The following is a description of a gene set: studied in species Homo sapiens from publication Hutcheson J, Scatizzi JC, Siddiqui AM, Haines GK 3rd, Wu T, Li QZ, Davis LS, Mohan C, Perlman H (PMID 18275831) Human Gene Set: GSE10325_LUPUS_BCELL_VS_LUPUS_MYELOID_DN Genes down-regulated in comparison of systemic lupus erythematosus B cells versus systemic lupus erythromatosus myeloid cells. Gene expression profile studies have identified an interferon signature in whole blood or mononuclear cell samples from patients with systemic lupus erythematosus. This study was designed to determine whether specific lymphocyte and myeloid subsets freshly isolated from the blood of systemic lupus erythematosus patients demonstrated unique gene expression profiles compared to subsets isolated from healthy controls., and this is the list of marker genes: DYNLT1, ZCCHC24, WDFY3, OAZ2, MACROH2A1, TPD52L2 (TPD52 like 2), NACC2, TSPO, MICAL2, FHOD1, NOD2, MPP1, BLVRB, CREG1, ALDH2, ATG7, ARHGEF40, ACTB, BLVRA, CYP1B1, FCGR1BP, GAA, MAFB, CYFIP1, ADGRE2, NCOA4, QSOX1, TBC1D2, IGSF6, PTPRE, CAP1, PSAP, ARHGEF10L, SLC36A1, DMXL2, PLXND1, RHOG, SLC11A1, NAIP, TIMP1, RAP2B (NCBI Gene Id 5912), HK3, TBC1D8, SERPINA1, LGALS3, GNAQ, LILRA2, LPAR6, HMOX1, GLUL, FCGR2A, HNMT, SLC22A4, PILRA, FCER1G, AIF1, SLC27A3, SMCO4, NCF2, KIAA0930, KCNMB1, ALDH3B1, ASGR1, GNS, SIGLEC7, LTBR, SIRPA, HPSE, TMEM127, SLC31A2, ETS2, ZMIZ1, CFP, CST3, KLF4, S100A4, VPS37C, ARHGAP26 (Rho GTPase activating protein 26), CPD, DOK2, PLXNB2, RXRA, GOLM1, SPG21, CEBPB, SCO2, CRISPLD2, TJP2, FBP1, CLEC4A, MAPKAPK3 (MAPK activated protein kinase 3), CTSB, TYROBP, PTTG1IP, SDCBP, MYO1F, MCOLN1, FLVCR2, CD163, CD93, PLOD1, APOBEC3A, HSPA6, TBXAS1, VAMP3, PECAM1, LILRA1, KIAA0513, RNF130, ARRB2, FCGRT, QPCT, ITGA5, CSF1R, RASSF4, ASB13, EPB41L3, MYOF, APOBR, HEXB, LRP1, GNA15, ST3GAL6, C3AR1, PLIN3, DUSP6, NPL, TNFRSF1A (NCBI Gene Id 8077), HSBP1, ATP6V1B2, TALDO1, TCF7L2, CTSA, TMEM164, TLR2, DAPK1, GALC, CLEC7A, BEST1, RTN4, CTSD, SAT1, APLP2, LILRB2 (NCBI Gene Id 10288), FEZ2 (NCBI Gene Id 9637), SECTM1 (secreted and transmembrane 1), LAMP1, RIN2, HEBP1, SLC16A5, NLRP3, C1orf54, LILRB1, FGL2, CTBP2, IL1RN, HK1, LST1, UPP1, ITGAM, CAMK1 (calcium/calmodulin dependent protein kinase I), ZDHHC7, IFNGR1, LILRB3, RAB32, ACVR1B, KCNJ2, P2RY2, TNFRSF1B, CARD9, RAB31, CFD, TNFAIP2, MSRB1, EFHD2, CEBPA, ADAP2, RAC1, TSEN34, KCTD12, S100A6, VCAN, ANPEP, MILR1, FTL, PSTPIP2, TGFBI, TLR5, HK2, SLCO3A1, CSF3R, C5AR1, SLC7A7, ACOT9, MARCO, STAB1, S100A11, RRAGD, PLAUR, CD36